The following is a description of a gene set: Human Gene Set: TDRD3_TARGET_GENES species: Homo sapiens from publication Yevshin I, Sharipov R, Kolmykov S, Kondrakhin Y, Kolpakov F (PMID 30445619) Genes containing one or more binding sites for (TDRD3) in their promoter regions (TSS -1000,+100 bp) as identified by GTRD version 20.06 ChIP-seq harmonization., and this is the list of marker genes: RPS6KB1, HEATR6, HEATR6-DT, TUBD1, LINC01719